Given this list of marker genes LNPPS, HMGXB3, DPYSL3, MIR145, PCYOX1L, LARS1, SPINK9, GRPEL2-AS1, RNU6-588P (RNA, U6 small nuclear 588, pseudogene), HTR4, SLC26A2, SH3TC2-DT, RBM27, SH3RF2, ADRB2, PPARGC1B, RNA5SP196, C5orf46, ABLIM3, AFAP1L1, SCGB3A2, ENSG00000275740, PDGFRB, ENSG00000300418, RPL29P14, PLAC8L1, SPINK1, RPL7P1, FBXO38, CARMN, MIR378A, RPL35AP17, RPL35AP16, PDE6A, ARHGEF37, TIGD6, PPP2R2B, RN7SL868P, STK32A-AS1, MARCOL, CSF1R, ENSG00000293883, RNU7-180P, SLC6A7, MIR584, JAKMIP2-AS1, POU4F3, SPINK5, HMGN1P16, PRELID2, GRXCR2, CAMK2A, SH3TC2, MFFP2, PGBD4P3, TRPC6P2, SPINK6, ASS1P10, RPS20P4, ENSG00000306902, JAKMIP2, SPINK7, STK32A, ENSG00000221043, SPINK13, GPR151, GRPEL2, TCERG1, RN7SKP145, SPINK14, KRT8P48, MIR143, ARSI, TCOF1, FBXO38-DT, RN7SL791P, CDX1, EEF1GP2, RNU6-732P, CSNK1A1, IL17B, PPP2R2B-IT1, here is a description of the gene set: species: Homo sapiens Human Gene Set: chr5q32